The following is a description of a gene set: Increased cup-to-disc ratio Human Gene Set: HP_INCREASED_CUP_TO_DISC_RATIO species: Homo sapiens An elevation in the ratio of the diameter of the cup of the optic disc to the total diameter of the disk. The optic disc has an orange-pink rim with a pale center (the cup) that does not contain neuroretinal tissue. An increase in this ratio therefore may indicate a decrease in the quantity of healthy neuroretinal cells., and this is the list of marker genes: MYOC, CYP1B1, ASB10, EFEMP1, CDH11, TEK, TRAPPC12, COL18A1